Given this list of marker genes DLD, DHTKD1, DLST, here is a description of the gene set: part of: Lysine catabolism The mitochondrial alpha-oxoadipate dehydrogenase complex (OADH, OADHC) catalyzes the overall reaction of 2-oxoadipate (OA), CoASH, and NAD+ to form glutaryl-CoA, CO2, and NADH. The complex contains multiple copies of three different enzymes, E1 (DHTKD1), E2 (DLST), and E3 (DLD), each with distinct catalytic activities. As in other dehydrogenase complexes, the lipoyl scaffold bound to DLST accepts the glutaryl moiety after the decarboxylation of OA by DHTKD1. Secondly, glutaryl is transferred to CoA by DLST, and finally, the dihydrolipoyl moiety is dehydrogenated by DLD using NAD+. Crystallographic studies show that in the OADH complex, DHTKD1 dimers bind to a 24-mer DLST core. species: Homo sapiens Reactome Pathway: OADH complex synthesizes glutaryl-CoA from 2-OA